The following is a description of a gene set: Any process that stops, prevents or reduces the frequency, rate or extent of synaptic vesicle exocytosis. Mouse Gene Set: GOBP_NEGATIVE_REGULATION_OF_SYNAPTIC_VESICLE_EXOCYTOSIS studied in species Mus musculus, and this is the list of marker genes: Fmr1, Syt4, Rap1b, Braf, Rap1a